The following is a description of a gene set: Mouse Gene Set: GOBP_PROTEIN_HETEROOLIGOMERIZATION The process of creating protein oligomers, compounds composed of a small number, usually between three and ten, of component monomers that are not all identical. Oligomers may be formed by the polymerization of a number of monomers or the depolymerization of a large protein polymer. species: Mus musculus, and this is the list of marker genes: Pkd2, Kcnc2, Sgta, Prph2 (NCBI Gene Id 19133), Calhm3, Pkd1, Krt1, Rrm2, Grin2b, Mat2a, Sgtb, Krt10, Farsa, Rom1, Mcur1, Ugt1a1, Syt1, Ski, Zfp746, Zfp777, Grin1, Gria3, Cpsf7, Cbr4, Col1a2, Farsb, Nudt21, Tmem120a, Rrm1, Hsd17b8, Cd2ap, Ugt2b1, Calhm1, Tmem120b, Cpsf6